The following is a description of a gene set: Human Gene Set: GOBP_OOCYTE_CONSTRUCTION studied in species Homo sapiens The synthesis, deposition, and organization of the materials in a cell of an ovary; where the cell can then undergo meiosis and form an ovum. An example of this is found in Drosophila melanogaster., and this is the list of marker genes: TDRD5, PLD6, TDRD1, TDRD6, FUT6, TDRD7, WDR77, TDRKH